Given this list of marker genes NLGN2 (neuroligin 2), NLGN4X, IL1RAPL1, NRXN1, PTPRD, LRP4 (NCBI Gene Id 4038), CNTN2, APOE, NLGN1, NLGN3, PTEN, here is a description of the gene set: studied in species Homo sapiens A process which results in the assembly, arrangement of constituent parts, or disassembly of a presynaptic membrane, including any proteins associated with the membrane, but excluding other cellular components. A presynaptic membrane is a specialized area of membrane of the axon terminal that faces the plasma membrane of the neuron or muscle fiber with which the axon terminal establishes a synaptic junction. Human Gene Set: GOBP_PRESYNAPTIC_MEMBRANE_ORGANIZATION